The following is a description of a gene set: Human Gene Set: GOMF_CYCLASE_INHIBITOR_ACTIVITY studied in species Homo sapiens Binds to and decreases the activity of an enzyme that catalyzes a ring closure reaction., and this is the list of marker genes: GNAZ (G protein subunit alpha z), GNAI1, ADGRV1, GRM7, NHERF4, RGS2